The following is a description of a gene set: Mouse Gene Set: GOBP_PROTOPORPHYRINOGEN_IX_METABOLIC_PROCESS The chemical reactions and pathways involving protoporphyrinogen IX, the specific substrate for the enzyme ferrochelatase, which catalyzes the insertion of iron to form protoheme. It is probably also the substrate for chlorophyll formation. species: Mus musculus, and this is the list of marker genes: Uros, Hmbs, Eif2ak1, Alas2, Cpox, Fech, Ireb2, Ppox, Alas1, Alad, Urod